Given this list of marker genes Gabbr1, Gpr156, Grm1, Ramp3 (receptor (calcitonin) activity modifying protein 3), Gabbr2, Ramp2, Calcrl, here is a description of the gene set: Mouse Gene Set: GOCC_G_PROTEIN_COUPLED_RECEPTOR_DIMERIC_COMPLEX A protein complex that contains two G protein-coupled receptors. studied in species Mus musculus